Given this list of marker genes NHLRC3, TMEM234 (transmembrane protein 234), GATM, PLAGL2, BSN, ZNF710, NRAS, SCN4B, C8orf58, C18orf21, ARG2, FRAS1 (NCBI Gene Id 84949), PXDN, ADRB3, SLC2A12, FGD6, SLC38A9, ANKRA2, DDI2, PCGF3, ENTREP2, ZNF280B, AEN, CD59 (CD59 molecule (CD59 blood group)), PTPRD, PPP1R15B, TTLL4, ENTPD7, NME6, CDKN1A, DNAAF9, THRSP, SRD5A3, FNIP1, DIP2A, XRN1, MED8, EEA1, PABIR1, AGAP1, LIN28A, FGF11, IQCB1, PEG10, CLDN12, CCND2, POLR3D, TAF9B, HMGA2, MAP3K1, HOOK1, LIPH, TSEN34, MIB1, SIGLEC5, AMT, CLDN16, FBXL12, PAPPA, STIMATE, DDX19B, RGS16, FNIP2, CPA4, MAPK8, PLEKHG6, SLC5A9, RUFY3, IGDCC4, KLF9, SPRYD4, AHCTF1, RGS6, OPA3, USP24, PDPR, ABCB9, ZBTB8B, MRS2, COL4A6, IGF2BP3, CPEB2, OSMR, NGF, MMS22L, E2F2, ABT1, ERCC4, CEP120, MARS2 (methionyl-tRNA synthetase 2, mitochondrial), CERCAM, DNAJA2, SKIL, INSR, SLC35D2, CD164, TECPR2, PIGA, ADRB2, PXT1, UHRF2, TRIM71, DTX4, ESR2, ZNF644, BZW1, AMOT, SIGLEC14, ARID3B, DPP6, IGDCC3, CPEB3, KCTD21, KIAA1958 (KIAA1958), CPEB1, DPH3, SLC22A23, GALNT2, ASAP1, UGCG, STRBP, LEPROTL1, LBR, DMD, LAMP2, GFM2, GALNT1, BEND4, RDX, TMOD2, SUB1, DCAF15, HAS2, CLP1, POGZ, GYG2, PALD1, WDR37, POGLUT1, STARD13, BIN3, KDM3A, KLHL31, MAPK6, ITGB3, PBX1, SLC31A2, SEMA4C, CCL7, GOLT1B, COL4A1, ACVR1C, KLHDC8B, RBFOX2, SENP5, IGF1R, PLEKHO1, MAP3K9, RICTOR, CRTAM, DDX19A, SLC25A27, ZBTB5, EIF4G2, COL4A2, SCN11A, MASP1, SENP2, IL13, C14orf28, MEIS2, WNT9B, SLF2, PRSS22, ARMT1, C19orf47, YPEL2, STX3, FRMD4B, ZCCHC9, GALC (NCBI Gene Id 2581), OSBPL3, HECTD2, RSPO2, CCNJ, SRGAP1, ACVR2A, ZNF516, LIPT2, COL1A2 (collagen type I alpha 2 chain), DNA2, NPEPL1, USP38, LIN28B, GJC1, TRANK1, KLF8, ZNF322, PARP8 (NCBI Gene Id 79668), TSPEAR, RAB8B, RIMOC1, TMEM167A, STK40, MAP4K3, HIF1AN, RFX6, TRIM67, NME4, ARHGEF38, HOXD1, CBX5, IMPG2, GAN, SEMA4G, ACER2, CDC34, FASLG, PLXND1, SOCS4, LINGO1, POLL, HSPA14, ZNF512B, EFHD2, E2F5, GAS7, HAND1, FIGNL2, PBX3, PARPBP, ARID3A, ERCC6, RANBP2, PEX11B, ACTA1, ZSWIM5, BEGAIN, FNDC3A (fibronectin type III domain containing 3A), USP44, DDTL, DCUN1D2, MBD2, CNTRL, COIL, TMEM65, ARK2C, PLPP5, KCNC2, RAB11FIP4, NAP1L1, PRPF38B, AGO4, PRLR, PLXNC1, RASGRP1, FIGN, ATP8B4, UTRN, CHD4 (NCBI Gene Id 1108), CADM2, ARL5A, DLST, NKAPD1, TNFSF9, XK, DUSP1, NR6A1 (nuclear receptor subfamily 6 group A member 1), GABBR2, ZNF689, PPP1R16B, TET3, HOXA1, SNX30, IGF2BP2, CEMIP2, B3GNT7, CNOT6L, YOD1 (YOD1 deubiquitinase), STARD3NL, VCF1, NIPAL4, EDN1, GPATCH2, HIP1, APBB3, SMIM3, ADAMTS15, E2F6, HDLBP, ELP1, FZD3, ZNF583, EDEM3, GXYLT1, COL3A1, CERT1, GDF6, GCNT4, SFMBT1, CARNMT1, TGFBR3, COL27A1, IGF2BP1, BACH1, FAXC, KCNJ11, DUSP22, FNDC3B, PCDH19, SLC16A9, ATOSB, ARHGAP28, VAV3, SCD, XYLT1, ADAMTS8, PTAFR, MYCN, CLCN5, IKZF2, XKR8, MEF2C, FAM135A, ATL2, PRTG, MTDH, GTF2I, SALL3, LRIG2, ZFYVE26, NPHP3, PLPP6, TMEM121B, DLC1, SMARCAD1, C15orf39, RALB, DTX2, GNPTAB, PLEKHA8, RNF20, SESTD1, THOC2, ZNF275, FZD4, CEP135, KCTD17, ERO1A, SLC10A7, TBKBP1, CASP3, PIK3IP1, LRIG3, CDC25A, DHX57, HDX, VIRMA, PBX2, SLC5A6, GNG5, DNAJC1, AP1S1, COL5A2, SALL4, TGFBR1, ATP2A2 (NCBI Gene Id 488), ABCC5, ZNF784, MFSD4A, GPCPD1, PLA2G3, EEF2K, ONECUT2, HIC2 (HIC ZBTB transcriptional repressor 2), IRS2 (insulin receptor substrate 2), PDE12, B4GAT1, DVL3, TMC7, AKAP6, SNX16, LIMD2, SMC1A, STARD9, LPGAT1, NEK3, KIAA0930, TMPPE, PGRMC1 (progesterone receptor membrane component 1), ACSL6 (NCBI Gene Id 56972), ABL2, SDK1, SLC20A1, GPR26, MDM4, ZBP1, TMPRSS2 (NCBI Gene Id 7113), NYNRIN, EPHA4, ELF4, here is a description of the gene set: from publication Chen Y, Wang X (PMID 31504780) Human Gene Set: LET_7A_5P_LET_7C_5P_LET_7E_5P Genes predicted to be targets of miRBase v22 microRNA hsa-let-7a-5p, hsa-let-7c-5p, hsa-let-7e-5p in miRDB v6.0 with MirTarget v4 prediction scores > 80 (high confidence targets). studied in species Homo sapiens